The following is a description of a gene set: Mouse Gene Set: MIR_7093_3P from publication Chen Y, Wang X (PMID 31504780) studied in species Mus musculus Genes predicted to be targets of miRBase v22 microRNA mmu_miR_7093_3p in miRDB v6.0 with MirTarget v4 prediction scores > 80 (high confidence targets)., and this is the list of marker genes: Nampt, Ell, Shisa9 (NCBI Gene Id 72555), Nrxn1, Gm3636, Nub1, Herpud2, Ncbp1, Slc5a3, Eya4, Slc17a3, Ndfip2, Sos1, Map1b, Gli3, Id4, Rab27b, Srd5a3, Rimoc1, Cnbp, Frmpd3, Chd1, Zfr, Xiap, Ank3, Cycs, Retreg1, Mdga2, Ehd3, Slc1a2, Pwp1, Tub, Atad2b, Aqp9, Cdyl, Gm3317, C1d, Clstn1, Rfx4, Sik1, Grm3, Chst5, Zfp9, Gm3383, Mpdz, Prl7a2, Ncor1, Tmem132b, Mark3 (MAP/microtubule affinity regulating kinase 3), Runx2, Marchf6 (membrane associated ring-CH-type finger 6), Il1a, Mtfp1, Esyt3, Fas, Nr2c2, Naaladl2, Gm5796, Rabggtb, 2610042L04Rik, Caprin1, Ucp3, Il7r (NCBI Gene Id 223338), Trim68, Hdhd2, Ctcf, Emp2, Dkk2, Gm3500, Slc7a13, Mis12, Gabra4, Cplane1, Synpo, Ro60, Smarca2, Mrgprb2, Rps6ka3, Bpnt2, Slc39a8, Pabpn1, Cast, Lzts3, Tyr, Nfia, Xylb, 1600012H06Rik (NCBI Gene Id 67912), Gm3696, Ewsr1, Rbms3, Adarb1, Atxn7, Orc1, Gm3411, Atg5, Gm3488, Rarg, Spred1, Frmd6, Mtmr9, Map4k2, Rrm2b, Mtrf1l, Fam193a, Kbtbd3, Dnaja2, D430041D05Rik, Hipk3 (NCBI Gene Id 15259), Mfsd4a, Ankrd22, Enpp1, Aadacl2fm1, Pmepa1, Mbnl3, Rufy2, Kcmf1, Kcnq5, Ube2d2a, Qser1, Msh4, Epha3, Gxylt1, Wnk2 (WNK lysine deficient protein kinase 2), Rplp0, Cux1, Dpp10, Ankrd27, Cdon, Glce, Tmem220, Gm2897, Samd4, Kcnj10, Txlng, Scai, Zfp788, Il17f, Prickle1, Btrc, Qrich1, Egln3, Mllt3, Plekhh2, Galnt2, Dennd1b, Gucy1a1, Scaf11, Osbp, Col11a1, Rab2a, Gid8, Zfp28, Rassf2, Npr2, Onecut2, Septin7, Pde1a, Acbd5, Skida1 (SKI/DACH domain containing 1), Hs6st1, Patj, Tmem65, Ogn, Nosip (nitric oxide synthase interacting protein), Rbm27, Mier3, Zic3, Mtmr10, Gpr143, Rnf4, Pde5a, Amtn, Sema5a, Crlf3, Eed, Zfp800, Fam120c, Gfra2, Gap43, Tns1, Antxr2, Rin3, Smyd4, Fibin, Polr3f, Cntn3, Upf2, Clvs1